Given this list of marker genes TOB1, ACYP2, PLOD3, ALDH9A1, SAP30L, MDM2, MTOR, CHUK, KAT14, CUEDC1, NGLY1, CLINT1, LGALS3BP, CREB3L4, CDC25A, EXOC6, ADCK2, SH3GLB1, DISP2, ZNHIT1, PUS10, TRIT1, ZNF326, SLC16A10, OXSM, HIC2, MEF2C, CALCOCO1, DYNLRB1, here is a description of the gene set: species: Mus musculus Human Gene Set: WAKABAYASHI_ADIPOGENESIS_PPARG_BOUND_36HR Genes with promoters bound by PPARG at 36 h time point of adipocyte differentiation of 3T3-L1 cells (preadipocyte). from publication Wakabayashi K, Okamura M, Tsutsumi S, Nishikawa NS, Tanaka T, Sakakibara I, Kitakami J, Ihara S, Hashimoto Y, Hamakubo T, Kodama T, Aburatani H, Sakai J (PMID 19414603) Control of cell differentiation occurs through transcriptional mechanisms and through epigenetic modification. Using a chromatin immunoprecipitation-on-chip approach, we performed a genome-wide search for target genes of peroxisome proliferator-activated receptor gamma (PPAR gamma) and its partner protein retinoid X receptor alpha during adipogenesis. We show that these two receptors target several genes that encode histone lysine methyltransferase SET domain proteins. The histone H4 Lys 20 (H4K20) monomethyltransferase PR-Set7/Setd8 gene is upregulated by PPAR gamma during adipogenesis, and the knockdown of PR-Set7/Setd8 suppressed adipogenesis. Intriguingly, monomethylated H4K20 (H4K20me1) levels are robustly increased toward the end of differentiation. PR-Set7/Setd8 positively regulates the expression of PPAR gamma and its targets through H4K20 monomethylation. Furthermore, the activation of PPAR gamma transcriptional activity leads to the induction of H4K20me1 modification of PPAR gamma and its targets and thereby promotes adipogenesis. We also show that PPAR gamma targets PPAR gamma2 and promotes its gene expression through H4K20 monomethylation. Our results connect transcriptional regulation and epigenetic chromatin modulation through H4K20 monomethylation during adipogenesis through a feedback loop.